The following is a description of a gene set: Genes down-regulated in memory CD8 T cells: 2' versus 3'. from publication Wirth TC, Xue HH, Rai D, Sabel JT, Bair T, Harty JT, Badovinac VP (PMID 20619696) studied in species Homo sapiens Human Gene Set: GSE21360_SECONDARY_VS_TERTIARY_MEMORY_CD8_TCELL_DN The transcriptome of naive OT-I T cells was compared to memory CD8 T cells after 1, 2, 3, or 4 infection with ovalbumin expressing Listeria monocytogenes (LM-OVA)., and this is the list of marker genes: RNF26, MFSD2A, EML3, DDX11, ASF1B, ASPSCR1, SLC29A3, TMEM86A, CD81, FGD2, NCAPD2 (non-SMC condensin I complex subunit D2), DIDO1, MICAL1, SLC14A1, FCGRT, PFKM, CX3CR1, INTS7, BUB3, IRAG2, EXO1, S1PR2, KLC4, SLC29A1, NXPE1, MXD4, LBH, PRKAG2, OTULINL, THUMPD2, HACD4, GUSB, GPR34, LIG1, LYSMD4, MYO7A, DHRS3, WDR41, HPS3, RAB3IL1, GPR33, COPZ1, SNORA73B, CNR2, TSPAN14, NOP2, TPCN1, PPP1R21, SLC46A1, GXYLT2, ABCA9, SLC25A26, NFATC2, KDM8, NRP1, TNIK, EVC2, TCF19, CKB, SLC1A6, CIITA, MBD5, CHST12, MCM5, GTF2I, SLC26A2, ALOX5AP, DAGLB, SLC25A53, ABTB3, SLC9A9, ELOF1, ABHD15, IL16, DOCK8, PIP5K1C, TADA2A, CEP295NL, NKRF, CD300A, ARL2BP, SEPTIN6 (NCBI Gene Id 23157), FASN, NEIL3, TMEM63A, HAAO, ADCY7, TUBB4B, ANAPC11, CXCR3, CMKLR1, SHLD2, LRRK1 (NCBI Gene Id 79705), MRGPRF, MTMR4, SRCAP, CSRP2, PCCB, TANGO6, MCM3, LMO2, EZH2, BUB1B, RPAP1, RNASE6, ABCC3, NCF1, SERTAD4, CCNJL, SNX19, CLSPN, ITPRIPL1, MARVELD1, GAL3ST4, RGS2, CENPA, PHLDA3, SNHG1, ANAPC1, CDC6 (cell division cycle 6), PLPP2, SLC36A1, LAIR1, PALD1, NFIC, FANCA, FMNL3, DIP2B, NUBP1, MAP4K1, RPS6KA1 (NCBI Gene Id 6195), WDR6, MEIS1, APCDD1, SNX29, STEAP3, DAPK1, VANGL2, TGFB3, LPAR6, CMTM3, MEF2C, CDH10, MCM7, SYT13, SUPT3H, FGD4, MAN1C1, CUTA, MAPK14 (NCBI Gene Id 1432), CAVIN1, TAFA1 (TAFA chemokine like family member 1), CSE1L, DERL3, ATP1A3, SHISAL2B, FKBP14, ACOX3, CFL1, RPP30, NBEAL2, TK1, CYP27A1, EMP3, GPR65, HGSNAT, CHTF18